Given this list of marker genes Mad2l1bp, Ska1, Ska3, Mad1l1, Prap1, here is a description of the gene set: studied in species Mus musculus Any process that stops, prevents, or reduces the frequency, rate or extent of negative regulation of mitotic spindle assembly checkpoint signaling. Mouse Gene Set: GOBP_NEGATIVE_REGULATION_OF_MITOTIC_SPINDLE_ASSEMBLY_CHECKPOINT_SIGNALING